Given this list of marker genes Ppp2r5e, Slc39a9, Rdh11, Gm35240, Six6, Scarna3b, Gm18899, Pigh, Gm9544, Churc1, D830013O20Rik, Mthfd1, Ppm1a, Rdh12, Gm24775, Gphn, 1300014J16Rik, Gm36660, Gm46364, Snapc1, 1700083H02Rik, Dhrs7l, Gphb5, Actn1, Hspa2, Gm4864, Dbpht2, Gm34552, Gm33016, Fut8, Rtn1, 2210039B01Rik, Mir5135, Kcnh5, Vti1b, Gm25563, Syt16, Trmt5, Gm47555, Gpr135, Ppp1r36, 4930442G10Rik, Gm7985, Tmem30b, Esr2, Mir1843a, Zbtb25, Prkch, Plekhh1 (NCBI Gene Id 97792), Gm33785, Gm34016, Gm26777, Ccdc177, Srsf5, Daam1, Ccdc175, Exd2, 4930474H06Rik, AI463170, 4933406B15Rik, Zbtb1, Ccdc196, Gm23817, Gm20337, Lrrc9, Galnt16, Gm34868, Tex21, 4930426I24Rik, Akap5, S100a11-ps, Gm5654, 2310002D06Rik, Gm25926, Rab15, Gpx2, Plek2, Gm8275, Gm24994, Gm35189, 9630002D21Rik, Plekhg3, Eif2s1, Arg2, Plekhd1os, Rplp2-ps1, Gm40438, Gm33929, Max, Gm35041, Gm8075, Mir5101, Pals1, 4930458K08Rik, 9530018F02Rik, Slc38a6, Rad51b, Zfyve26, Mnat1, Garin2, A430103D13Rik, 2310015A10Rik, Tmem229b, Ppp1r36dn, Plekhd1, Hif1a, Sptb, Gm7862, Syne2, 9230116L04Rik, Atp6v1d, Gm7986, Gm8219, Rhoj, Erh, Wdr89 (NCBI Gene Id 72338), Susd6, Six1 (sine oculis-related homeobox 1), Zfp36l1, L3hypdh, Gm15283, Fntb, Dact1, Gm8255, Gm24070, 1700086L19Rik, 9430078K24Rik (RIKEN cDNA 9430078K24 gene), 4930447C04Rik, Sgpp1, Gm30025, Pcnx4 (pecanex homolog 4), Ly6e-ps1, Dcaf5, 1700052I22Rik, Jkamp, Six4, Dhrs7, Gm18243, here is a description of the gene set: species: Mus musculus Mouse Gene Set: chr12C3